The following is a description of a gene set: Human Gene Set: GOMF_DEATH_DOMAIN_BINDING Binding to a death domain of a protein. The death domain (DD) is a homotypic protein interaction module composed of a bundle of six alpha-helices. DD bind each other forming oligomers. Some DD-containing proteins are involved in the regulation of apoptosis and inflammation through their activation of caspases and NF-kappaB. studied in species Homo sapiens, and this is the list of marker genes: BAX, RIPK1, MCL1, BCL2, RACK1, IRGM, CRADD, TRADD, BCL2L1 (NCBI Gene Id 598)